Given this list of marker genes BHLHE40, PRKG2, OAS3, ADAMTS4, CTH, CSRNP1, UPP1, SOCS3, COPE, IFI44, CXCL2 (NCBI Gene Id 2920), PDK1, IL6, ADAMTS1, AK4, ACOX2, HAX1, ERO1A, FTH1, RAMP3 (NCBI Gene Id 10268), PGM1, PLEK, HOXB9, GBE1, RSAD2, HELT, PTGS2, VLDLR, SLPI, BNIP3, FAM162A, MAFF, CNOT7, here is a description of the gene set: Human Gene Set: GROSS_ELK3_TARGETS_DN The ternary complex factor Net/Elk3 is downregulated in hypoxia and participates in the induction by hypoxia of several genes, including c-fos, vascular endothelial growth factor and egr-1. However, the global role of Net in hypoxia remains to be elucidated. We have identified, in a large-scale analysis of RNA expression using microarrays, more than genes that are regulated by Net in hypoxia. In order to gain insights into the role of Net in hypoxia, we have analysed in parallel the genes regulated by HIF-1alpha, the classical factor involved in the response to hypoxia. We identified about genes that are regulated by HIF-1alpha in hypoxia. Surprisingly, when we compare the genes induced by hypoxia that require either Net or HIF-1alpha, the majority are the same (75%), suggesting that the functions of both factors are closely linked. Interestingly, in hypoxia, Net regulates the expression of several genes known to control HIF-1alpha stability, including PHD2, PHD3 and Siah2, suggesting that Net regulates the stability of HIF-1alpha. We found that inhibition of Net by RNAi leads to decreased HIF-1alpha expression at the protein level in hypoxia. These results indicate that Net participates in the transcriptional response to hypoxia by regulation of HIF-1alpha protein stability. studied in species Mus musculus from publication Gross C, Dubois-Pot H, Wasylyk B (PMID 17704799) Genes down-regulated in SEND cells (skin endothelium) at normal oxygen (normoxia) conditions after knockdown of ELK3 by RNAi.